The following is a description of a gene set: The intramolecular conversion of uridine to pseudouridine in a tRNA molecule. species: Mus musculus Mouse Gene Set: GOBP_TRNA_PSEUDOURIDINE_SYNTHESIS, and this is the list of marker genes: Pus1, Pus3 (NCBI Gene Id 70483), Pusl1, Pus10, Pus7, Rpusd4 (NCBI Gene Id 71989)